Given this list of marker genes Rsrp1, Btg2, Evl, Il16, Cd300c2 (NCBI Gene Id 140497), Itm2b, Tsc22d3, Man2b1, Ptpn18, Eef1d, Ppp1r15a, Arhgap45, Klhl24, Tut4, H1f2, Lipa, Kctd14, Treml4, Aph1c, Ubb, Mxd4, Lpin1, Hbp1, Septin6, Map4k4, Jun, Trim35, Cytip, Snx5, Dusp1, Plp2, Ucp2, Rgs1, Hspa1b, Ttc39a, Tnrc6b, Hspa1a, Dhrs1, Tnfaip8, Slc66a2, Alox5ap, Klf2, Kctd12, Tm6sf1, Pstpip1, Erp29, Npc2, Stx17, Ifngr1, Rab7b, Cox7a2l, Tsc22d4, Celf2, Fnbp1, Cd81, Niban1, Dlgap4, Nr4a1, Syne1, Pold4, Plin2, Sgk1, Fosb, Creg1, Pdcd4, Paip2, Gpi1, Eef2, Uba52 (NCBI Gene Id 56512), Tm2d3, Otulinl, Adrb2, Ivns1abp, Sat1, Cir1 (NCBI Gene Id 74817), Rgs10, Ypel3, Zfp36l2, Nr4a2, Gpr65, Pcbp2, Rab11fip1, Atraid, Tubb2a, Rgs2, Ctdp1, Inpp5d, Tep1, Cxcr3, Fos, Clk1, Srsf11, Ankrd44, Klf4, Ppfia4, Rhob, Pid1, Supt20, Pmaip1, Hepacam2, BC028528, Gdi2, Trf (transferrin), here is a description of the gene set: from publication Cui A, Huang T, Li S, Ma A, Pérez JL, Sander C, Keskin DB, Wu CJ, Fraenkel E, Hacohen N (PMID 38057668) Cytokines mediate cell-cell communication in the immune system and represent important therapeutic targets. A myriad of studies have highlighted their central role in immune function, yet we lack a global view of the cellular responses of each immune cell type to each cytokine. To address this gap, the authors created the Immune Dictionary, a compendium of single-cell transcriptomic profiles of more than 17 immune cell types in response to each of 86 cytokines (>1,400 cytokine-cell type combinations) in mouse lymph nodes in vivo. A cytokine-centric view of the dictionary revealed that most cytokines induce highly cell-type-specific responses. For example, the inflammatory cytokine interleukin-1β induces distinct gene programmes in almost every cell type. A cell-type-centric view of the dictionary identified more than 66 cytokine-driven cellular polarization states across immune cell types, including previously uncharacterized states such as an interleukin-18-induced polyfunctional natural killer cell state. Mouse Gene Set: CUI_CDC1_IL2_RESPONSE_DN Genes negatively differentially expressed in cell type: cDC1 (conventional dendritic cell type 1) upon treatment with cytokine: IL-2 in mouse lymph nodes in vivo. studied in species Mus musculus